Given this list of marker genes Ift70b, Ift52, Ift57, Cluap1, Ift81, Ift70a1, Ift80, Ift22, Ift56, Ift88, Ift46, Ift27, Ift20, Wdr19, Ttc21a, Wdr35, Ift70a2, Traf3ip1, Ttc21b, Rabl2, Ubxn10, Ift140, Ift122, Trim59, Ift43, Ift74, Ift172, Ift25, here is a description of the gene set: A nonmembrane-bound oligomeric protein complex that participates in bidirectional transport of molecules (cargo) along axonemal microtubules. studied in species Mus musculus Mouse Gene Set: GOCC_INTRACILIARY_TRANSPORT_PARTICLE